The following is a description of a gene set: The lipid bilayer surrounding any of the compartments that make up the trans-Golgi network. Human Gene Set: GOCC_TRANS_GOLGI_NETWORK_MEMBRANE studied in species Homo sapiens, and this is the list of marker genes: CLTC, CRACR2A, HLA-DRA, SCAMP3, COG6, SCAMP5 (NCBI Gene Id 192683), HLA-DQB2, GNAS, ATP7B, COG5, AFTPH, CABP7, VTI1A, AP1S2, MMP24 (NCBI Gene Id 10893), AP1S3, NDST1, FUT9, LGR6, HLA-DQB1, VPS51, STX6, HTR7, RAB31, COG7, COG2, BAIAP3, HLA-DQA2, SLC30A6, AP4B1, RAB9A, MARCHF1, RAB8A, AP4E1, IGF2R, VPS54, BOK (BCL2 family apoptosis regulator BOK), RABEPK, COG1, CLIP3, AP1M2, COG8, SCAMP4, LGR5, TEPSIN, CD74, HLA-DRB5, FCMR, ARL1, HLA-DPA1, COG4, ATP7A, VPS52, HLA-DRB3, NSG2, AP1G1, CLTA, VPS13B, SCAMP2, APP, HLA-DQA1 (major histocompatibility complex, class II, DQ alpha 1), AP1B1, ATP9A, ASAP1, BPNT2, CLVS1, GOLPH3L, SYS1, MYO1B, ATP2C2, RGP1, PICK1, ST3GAL1, RAB43, SLC30A5, ARFIP2, SLC24A5, AP1M1, NSG1, RIC1, HLA-DRB1, AP1S1, HLA-DRB4, RAB6A, CLBA1, SLC9A8, SCAMP1, HLA-DPB1, VAMP3, CLVS2, TMEM165, RAB11FIP3, KIF13A, CD2AP, VPS53, ARFRP1, STX10, TMEM79, ARFIP1, M6PR, RAB11A, AP4S1, LLGL1, RHOBTB3, AP4M1, STX16, PLD4, VAMP4, USP6NL, COG3, CALN1